Given this list of marker genes ITGB1, PRSS37, PDILT, DMRT1, TGFB1, FOXC1, TGFBR1 (NCBI Gene Id 7046), KIT, CXADR, here is a description of the gene set: The orderly movement of a cell specialized to produce haploid gametes through the embryo from its site of production to the place where the gonads will form. Human Gene Set: GOBP_GERM_CELL_MIGRATION species: Homo sapiens